The following is a description of a gene set: Mouse Gene Set: CUI_TREG_NEUROPOIETIN_RESPONSE_UP Cytokines mediate cell-cell communication in the immune system and represent important therapeutic targets. A myriad of studies have highlighted their central role in immune function, yet we lack a global view of the cellular responses of each immune cell type to each cytokine. To address this gap, the authors created the Immune Dictionary, a compendium of single-cell transcriptomic profiles of more than 17 immune cell types in response to each of 86 cytokines (>1,400 cytokine-cell type combinations) in mouse lymph nodes in vivo. A cytokine-centric view of the dictionary revealed that most cytokines induce highly cell-type-specific responses. For example, the inflammatory cytokine interleukin-1β induces distinct gene programmes in almost every cell type. A cell-type-centric view of the dictionary identified more than 66 cytokine-driven cellular polarization states across immune cell types, including previously uncharacterized states such as an interleukin-18-induced polyfunctional natural killer cell state. Genes positively differentially expressed in cell type: Treg upon treatment with cytokine: NP in mouse lymph nodes in vivo. from publication Cui A, Huang T, Li S, Ma A, Pérez JL, Sander C, Keskin DB, Wu CJ, Fraenkel E, Hacohen N (PMID 38057668) studied in species Mus musculus, and this is the list of marker genes: Ly6a, Stat2, Rtp4, Ifi206, Ifi208, Grk6